Given this list of marker genes Hrh2, Atp5pf (NCBI Gene Id 11957), Acsl4, Pla2r1, Agtr2, here is a description of the gene set: species: Mus musculus Mouse Gene Set: GOBP_NEGATIVE_REGULATION_OF_ICOSANOID_SECRETION Any process that stops, prevents, or reduces the frequency, rate or extent of the controlled release of an icosanoid from a cell.